Given this list of marker genes FLT3LG, C1S, PML, PARP12, PJA1, STAT1, SQOR, DNPEP, C5orf15, IFI27 (interferon alpha inducible protein 27), PDGFRL, SECTM1, APOL6, APOL3 (apolipoprotein L3), IFI35, LAP3, HLA-C, IFI6, FAS, DRAM1, H2BC17, CMTR1, IGFLR1 (IGF like family receptor 1), IRF1, TRIM14, PHF11, TMEM62, TRIM5, SEMA3F, GSTK1, CFH, XPO6, IRF8, PRKD2, APOL2, SLC25A22, NFKBIA (NFKB inhibitor alpha), POU5F1B, CASP8, KDM6A, TRIM38, MX1, IRF7, OAS2, CXCL2, C1R, CTNNBL1, HCP5, HLA-G, MYD88, FOSL2, IFIT2, BATF3, HLA-B (NCBI Gene Id 730410), LTBR, PLSCR1, TAP2, CFB, TLR3, OASL, IFI44L, BACH1, MAX, DOCK4, ISG20, LAMP3, LMO2, OAS3 (NCBI Gene Id 4940), NPC1 (NPC intracellular cholesterol transporter 1), TRIM31, SHFL, GPATCH1, GUK1, ISG15, P4HA1, MCL1, LGALS3BP, NFE2L3, DOP1A, TRIM21 (NCBI Gene Id 6737), TAPBP, IFIH1, UBE2L6, ZNF22, GPR18 (G protein-coupled receptor 18), ADGRE1, IFI16, RASGRP3, JADE2, CBR3, CTSS, RUBCN, OPTN, RBM7, SERPING1, PSME2, PARP3, PSMB9, B2M (beta-2-microglobulin), ZFP36, ZNF710, SAMHD1, RIGI, GBP1, TMEM140, HLA-E, NUCB1, BTN3A2, RNF19B, PSMA4, STAT3, BCL2L13, DDX60, IFIT1, CDK18, IFIT5, EXT1, UBA7, IRF9, IDO1, SEPTIN4, IFI30, C3, CASP7, USO1, RNF114, CTSL, LY6E, ATP10D (NCBI Gene Id 57205), TGM2, HLA-F, RBMS1, IFITM2, FAM111A, IL32, ERAP1, HLA-K, RBCK1, TAPBPL, LPIN2, TDRD7, TAP1, TRIM22, TASOR2, IGFBP3, TRAFD1, RTP4, CD38, SPATS2L, MX2, PSMB3, OGFR, HERC5, HLA-J, HLA-A, SP110, TFG, PLAUR, SLC15A3, BST2, TNFSF10, WARS1, IL6ST, CASP1, CDC42EP4, NMI, SLC2A3, ADAR, IFIT3, SLC25A28, FADD, HERC6, ST8SIA4, PPA1, RPS6KA5, ASPM, OAS1, SERPINB9, USP18, USP15, TCIRG1, ADAP1, CD47, PLAAT4, CNDP2, SP100, PSMA6, ITM2B, GTPBP1, APOL1, LEPROTL1, TRANK1, CALCOCO2, PSMB8, PSME1, IFITM1, IFI44, TYMP (thymidine phosphorylase), TRIM25 (NCBI Gene Id 7706), PSMB10, here is a description of the gene set: Human Gene Set: GSE42021_CD24HI_VS_CD24INT_TREG_THYMUS_DN from publication Toker A, Engelbert D, Garg G, Polansky JK, Floess S, Miyao T, Baron U, Düber S, Geffers R, Giehr P, Schallenberg S, Kretschmer K, Olek S, Walter J, Weiss S, Hori S, Hamann A, Huehn J (PMID 23420886) species: Homo sapiens We investigated at which stage of maturation commitment to a stable Foxp3-expressing phenotype takes place. We assessed stability of Foxp3 expression in thymic Foxp3+ Treg subsets of different maturity, defined by CD24 expression. Next we compared gene expression profiles of Foxp3+ Treg subsets (+) of different maturity (24lo, 24int, 24hi) and could identify a set of genes that were specifically up or downregulated in Foxp3+ Tregs, but not in Foxp3- conventional T cells, in a maturation-dependent manner. Genes down-regulated in thymic T reg: CD24 high versus CD24 int.